Given this list of marker genes BBS2, CEP290, DKC1, GATA1, POU6F2, H19 (NCBI Gene Id 14955), NRAS, RPS24, SRY, BBS5, FGFR2, RPS15A, RPS7, SLX4, MYCN, CHST14, NPHP1, IFT74, ARL6, DSTYK, TCTN3, SMOC1, SON, TTC8, SMARCE1, RPS17, RARB, BBS12, ARID1B, AFF4, SCLT1, SEMA3E, ESCO2, IFT27, AFF3, RPS29, RPL35, RBM8A, BBS10, STRA6, BBS1, DYNC2LI1, RPS10 (NCBI Gene Id 6204), ADAMTS3, HMGA2, CHD7, RPL35A, RPL5, PUF60, CEP19, POR, MRPS34, SCAPER (S-phase cyclin A associated protein in the ER), SOX4, GPC3, WT1, ZIC3, RPL9, RPS20, ADA2 (NCBI Gene Id 51816), IFT172, MNX1, HNRNPU, TRIP13, RPL8, SOX11, CCNQ, PALB2, UBE2A, ARID2, DDX59, CHUK, CC2D2A, CD96, FANCI, RPL11, TRIM28, ARID1A, THOC6, COLEC11, NIPBL, SDCCAG8, PAX2, STAG1, EBF3, SNRPB, DSE, MKS1, RBM10, LZTFL1, RPS27, COLEC10, PBX1, REST, KDM6A, RPL26, ZMYM3, PORCN, RPL27, DIS3L2, EXTL3, HRAS, HEATR3, RPS26, GRB10, FANCC, KMT2D, BBIP1, SSR4 (signal sequence receptor subunit 4), SMARCC2, CAPN15, HNRNPH1, WNT7B, BMPER, SC5D, WDPCP, FAT4, RPL18, RPL31, CCBE1, MAP3K7, SMARCB1, BBS9, CFAP418, SMARCD1, DPF2, FANCA, RPL15, RAP1GDS1, FANCE, SALL4, TSR2, BICRA, FANCD2, ZFX, SMARCA4, RPS28, BBS7, KAT5, UBA2 (ubiquitin like modifier activating enzyme 2), HNF1B, BRCA2, TRIM32, MKKS, RPS19, KRAS, GREB1L, DDB1, CWC27, LEMD3, BBS4, here is a description of the gene set: Horseshoe kidney species: Homo sapiens A connection of the right and left kidney by an isthmus of functioning renal parenchyma or fibrous tissue that crosses the midline. Human Gene Set: HP_HORSESHOE_KIDNEY